Given this list of marker genes LILRA4, DTX3L (NCBI Gene Id 151636), IL6R, GBP2, IL22RA2, PROS1, IGF1, MCU, FPR2, EPHA4, CCL21, PDCD4, FLOT1, KCNK13, WNT4, SEMA5A, PRDX2, FFAR4, IRGM, ZNRF1, ANXA1, ALOX5, MAP3K8, HLA-B, CEACAM1, SIRT2, FCRL3, AREL1, EFNB2, NLRC5, VPS35, TNFRSF11A, TRIL, MIR21, PRKD2, LACC1, PLCG1, MICOS10-NBL1 (NCBI Gene Id 100532736), NKG7 (natural killer cell granule protein 7), MIR140, TRPV4, ARTN, CLPB, SETD6, IRF5, RNF31, APOA1, CALHM6, PGLYRP2, RB1, MIR520B, PYDC5, ADAM17, RARRES2, ADORA2A, JAK2, GSDMD, GNAS, TRIM38, CD96, MMP3 (NCBI Gene Id 4314), SUCNR1, STAT5B, DHX9, STAT3, RNF26, AP3B1, CCL4 (C-C motif chemokine ligand 4), CD36, CD47, ENPP3, KLKB1, SPHK1, ARMH4, PTPRC, CAMKMT, CASP1, PPARA, DAGLB, IRF7, STMP1, NLRP12, CASK, SHARPIN, XCL1, IL17A, CDH5, FCGR2B, CCR6, CPT1A, SLC39A8 (NCBI Gene Id 64116), PJA2, PYCARD, ABCC1, ANXA2, PSMA6, TLR2, FOSL1, NAGK, JAM3, MIR181B1, APCS, SH2D1B (NCBI Gene Id 117157), NMT1, IL6ST, IFIH1, MAPK14, DTX4, IL37, MOSPD2, APPL2, SQSTM1, TSPAN32, LAMP1, AIF1, UFL1, C5, ELF4, CTTN, AKIRIN2, DRD2, PHB1, HPX, NFKB1 (NCBI Gene Id 4790), FGF4, CD109, LETMD1, IL18RAP, ZDHHC5, MIR200C, RAC2, PLA2G2A, FYN, HLA-DRB1, OAS3, PLA2G2D, SOCS5, ACOD1, NCR1, APOE, MGLL, HDAC6, GRK7, GDI1, APPL1 (adaptor protein, phosphotyrosine interacting with PH domain and leucine zipper 1), STING1, RAB11FIP2, MIR708, CAMK2N1, TMX1, SLC15A4, PLAT, TRAF3, MIR16-1, YWHAE, STX3, HCK, SNCA, DHX58, PGF, A2M, AIM2, SERPINB9, TEK, PTK2, GNAT1, PELI1, GATA6, ABHD12, CPTP, CHD8, MFHAS1, RTN4, SLC15A2, TRIM32, PGC, TAC1, SPI1, DNASE1 (deoxyribonuclease 1), BCL6B, MIR31, IL17RB, IKBKB, TLR8, UBQLN1, DUSP3, PQBP1, INAVA, MIR206, S100A8, TNFSF18, MIR138-1, DAGLA, CD274, NT5E, MIR30C2, HAVCR2, DEFB131A, GUCY2D (NCBI Gene Id 8145), CORO1B, CARD9, USF1, METTL3, MAP2K1, VEGFD, IRAK2, ITGA2, IRF3, WNT3, PTGIS, SERPING1, RHBDD3, PTGER4, CASP6, AURKB, ZDHHC1, FGF18, CD55, ATG12, RNF125, PPP2CA, MIR431, KRT1, RIPK2, PIK3R1, LYPLAL1, DDX3X, PTPN11, WFDC1, SERPINB4, TIGIT, ADORA2B, TLR10, MMP8, NTRK3, HEXIM1, SELENOK, CEBPB, TNFAIP6, CNTF, MMP28, SFPQ, MMP9, FGG, BMP6, HLA-F, CXCR3, TLR7 (toll like receptor 7), TAFA3, FGF10, UFD1, VAMP3, SOX15, ARNT, PPP1R13L, NPLOC4, MIR22, IFNLR1, PLA2G7, KLRD1, DDX39A, TMEM126A, TNC, RAET1E, RTCA, RIPOR2, LRRK2, TNIP1, MIR424, SERPINC1, RBM47, GRK4, SHPK, IFNG, FNDC4, VAMP2, SLIT2, HERC5, DVL1, GGT2P, HSPB1, NDFIP1, DDX60, HRG, MIR361, POU4F2, TYROBP, IL21, TRIM3, NOP53, KLRC3, GPS2, SEMA3F, RPS19, CXCL13, REG3G, YTHDF3, TRAF3IP3, AKT1, MIR15B, IL1R1, SLC8B1, IL12RB1, DUSP10, THBS4, BRCC3, INPP5D, PUM1, MIR146A, FUT7, ARRB2, NLRP4, CD300E, CCL19, NAIP, LRIG2, IDO1, MARK4, DSCAM, EXTL3, CX3CR1, MYCBP2, TLR3 (toll like receptor 3), PGLYRP1, KIR2DS2, YWHAZ, GP1BA, SIGLEC16, PYDC1, MUL1 (NCBI Gene Id 79594), FOXF1, TICAM2, VTN, HCFC2, IL4, CYBA, EMILIN1, CASP12 (caspase 12 (gene/pseudogene)), IL20, CYRIB, MIR766, MIR19A, PIK3CG, MIR657, MAPK8, POMC, MBL2, MET, DDX41, LBP, PPARD, ZNFX1, TRAFD1, RICTOR, KLRB1, GFI1, ABHD8, CCN3 (NCBI Gene Id 4856), RNF115, EIF2AK4, CD37, APOBEC3F, DUSP1, PTGER3, BRD4, LGALS9, CD160, FGR, NLRP7, TNIP2, KLK5, LILRA2, CAMK1D, NEO1, PIK3AP1, TICAM1, DNM1L, PTPN22, ADAMTS18, MIR205, GHRL (ghrelin and obestatin prepropeptide), SCIMP, IFNK, MED1 (mediator complex subunit 1), PLK2, SIGIRR, IL1RL1, AZU1, FFAR3, NMT2 (N-myristoyltransferase 2), SEC14L1, FLOT2, HPSE, POLR3G, RASGRP1, FGFR1, TRAF3IP2, PERP (NCBI Gene Id 64065), EPPK1, NLRP5, SNX6, CD300A, CD180, C5AR2, PVR, MTUS1, EPHB2, VAMP7, HSPA1B, ESR1, PLA2G3, CARD16, TAFA5, PHB2, NLRC3, MIR4286, NLRP6, CLEC7A, GUCY2F, MIR19B1, PLAU, LPL, CTSC, CNTNAP2, CLEC12B, MIR200B, ACE2, GKN2, PSMA1 (NCBI Gene Id 5682), GPR108, MAP3K7, AOAH, ADORA1 (adenosine A1 receptor), GPR4, OSM, TASL, C2CD4A, IL1B (NCBI Gene Id 3553), YES1, NT5C2, ADAM8, GGT1, PAK1, NLRX1, RAC1, HMGB1, MYOZ1, CD81, SLIT1, ZP3, APOH, MARCHF5, MAPK7, OXSR1, AIPL1, AJAP1, ROBO1, HLA-E, OTUD4, MIR223, SCARA3, TPBG, TMEM102, C2CD4B, USP27X, MPP1, GRB2, CSF1, FEM1A, ATOH7, RBM14, MIR20A, LSM14A, EPG5, KAT5, NBL1, TARBP2, MIR181A2, LACRT, GIGYF2, N4BP1 (NCBI Gene Id 9683), IL10RA, KCNJ8, GRN, KIR2DL4, CTSS, PARP14, BRAF, CLASP1, IER3, NR1H2, TNFAIP3, CCL3, LILRB1, SH2D1A, NECTIN4, SMIM30, NFKBIA, TREM2, SERPINE1, RNF34, PML, USP38, UBASH3B, PTPRJ, MIR920, IL17F (NCBI Gene Id 112744), PDGFA, MIR145, ADGRA2, ERAP1, IL1RL2, MIR4691, DROSHA, CXCL17, NR1D2, KLK3, MEFV, C3AR1, EDN1, VSIG4, TRIM21, YTHDF1, CCL24, AGER, SLC6A3, FOXP3, AGTR1, GSTP1, PDPK1, TRIM22, TMSB4X, NFKBIL1, CXCL6, PBK, ELMOD2, XRCC6, FANCA, APOBEC3G, IKBKE, FADD, LY86, POLR3D, LYAR, NONO, NOTCH1, IL34 (interleukin 34), HSP90AA1, NRP1, PLAUR, LGALS2 (NCBI Gene Id 3957), CD226, NCF1, TRIM56, S100A12, CREB3L3, ASH1L, TTBK1, EIF2AK2, NR1H3, MICA, RNF144A, PSMB4, MACIR, TLR5, MAVS, FAM76B, CASP4, DRD3, SELENOS, CD9, SBNO1, POLR3C, SIN3A, LPAR1, TSPAN8, TNR, VEGFB, NFE2L1, F2, GATA3, RGMA (NCBI Gene Id 56963), IL23R, CSNK1A1, KLRK1 (NCBI Gene Id 22914), SCGB1A1, CD74, PLXNA3, PIM1, ZC3H12A, RORA, BAP1, FABP4, IL18, NTF3, MIR149, TUBB2B, SNX4, PYHIN1, ZMPSTE24 (NCBI Gene Id 10269), MIR590, METRNL, OTULIN, PAK3, ZDHHC4, MYD88, PROC, F2RL1, HSP90B1, NPY5R, SCARF1, USP17L2, ALOX12 (arachidonate 12-lipoxygenase, 12S type), OASL, F12, PF4, NR5A2, MIR3909, SMPDL3B, BIRC3, TRIM15, GRAMD4, IL15, ADTRP, SARM1, CD1D, POLR3B (RNA polymerase III subunit B), SBNO2, XRCC5, NUPR1, SLC15A3, TLR4, GBP5, AHSG, CMA1, ZDHHC18, CNOT7, GGT3P, RIN3, F11, TIRAP, USP50, SPAAR, TREX1, NOD1, OGT, WNT5A, SLC19A1, PLXNA4, ZCCHC3, CLEC4E, EDN2, NFKBIZ, IFI16, PCBP2, TRIM41, TNFSF11, ITCH, SLAMF6, NCKAP1L, AKNA, GPR31, TIFAB, CCDC134, SETD4, TRIM44, CR1, SERPINF2, MIR26A1, GAS6, IRF1, FURIN, SMAD3, RHBDF2, CYLD, GPR17, GPX1, IRAK1, MVK, TNIP3, PTPN6, SASH1, OSMR, MIR144, MAP2K2, DEFB118, UNC93B1, KLF4, ROBO2 (NCBI Gene Id 90370), LATS1, BCL10, PTPRS (NCBI Gene Id 5802), MMRN1, USP18, MIR92A1, VEGFC, PTEN, ANO6, SCG2, CRK, CAV1, ATG5, LPCAT3, PPP2R3C, KREMEN1, CFH, WASHC4 (WASH complex subunit 4), FGF2, PDGFB, FIGNL2, MIR195, MIR199A1 (NCBI Gene Id 406976), RNF39, USP29, GHSR, DSG2, CCDC92, TBK1, CXCL12, CALR, FCGR1A, TXK, CASP8, STX4, ADAM10, TLR6, FCER1G, GRIN3A, HLA-A, CDC37, SIGLEC10, LATS2, FAP, NINJ1, NLRP14, CLNK, ST3GAL4, MIR17, CSF1R, FGB (NCBI Gene Id 2244), IRF4, CXCL10, SPP1, MIR15A, LRFN5, CD300LF, F2R, CAPN3, IL22, TRIM62, IFI35, OTOP1, TSPAN6, CLEC12A, NPY, BCL6 (BCL6 transcription repressor), PPARG, PYDC2, BTK, C3, RASGRP4, C5AR1, ACP5, POLR3F, PPM1B, ERCC6, EIF4E2, MIR222, ZNF580, ISG15, PAK2, TRIM11, RSAD2, TRAF3IP1, SLC12A2, COLEC10, MIR105-1, CD300C, GIT1, TRIM31, CREBBP, CPB2, PARK7, MAPKAPK3, EP300, PLSCR1, SLC46A2, USP15, SYT11, DNASE1L3 (deoxyribonuclease 1L3), GJD4, TNFSF4, ADAR, CCL2, NEDD9, MIR488, NLRP13, TNFSF14, WDFY1, IL10, IFNB1, BECN1 (beclin 1), DPP4, ZDHHC12, RIPK1, HGF, TAX1BP1 (Tax1 binding protein 1), PTPRO, MIR6869, TRIB1, P2RY12, PDGFRA, BIRC2, TRAF6, LRCH4, NR1D1, STAP1, TNFRSF1A, SLAMF1, FGF16, PRKCD, F3 (NCBI Gene Id 99486), CRTAM, IL2RA, COLEC11, CCN4, PDGFD, NEK7, KLRC4-KLRK1, CCL5, PLG, PARP9, NOS3, XIAP, COLEC12, GBA1 (NCBI Gene Id 82008), FANCD2, IL6, SERPINE2, GRK1, MIRLET7G, WNK1, STAT1, P2RX7, TOMM70, DRD1, TNF, STAT5A, RIGI, ZNRF4, NLRP9, IRAK4, ABHD17A, PARP1, ARG1, PSPC1, MIR34A, NLRP2, FAM3A, PHLDB2, AKIRIN1, PRKCE, INS, THBD, SOCS3, KLRC1, LYN, IL27, TAB1, PTPN1, CACTIN, HMGB2, IL12A, PTGES, TTLL12, S100A9, SPSB3, EVPL, RTN4RL1, MDK, CASP5, KARS1, LGALS1, VAMP8, BACE1, ETS1, ZBP1, NEAT1, STK39, CCR7, MIR187, MICB, IL17RA, SWAP70, NMI, SFN, ILRUN (inflammation and lipid regulator with UBA-like and NBR1-like domains, NCBI Gene Id 79138), KDR, SYK, SLAMF8, MMRN2 (NCBI Gene Id 79812), PPM1F, AP1G1, ROBO3, NAPEPLD, SMOC2, SPATA2, PTK2B, IL23A, FEZF2, NLRP10, GPRC5B, IPO5, KLRC2, MAPKBP1, GRID2, GBP1, EDNRB, SOD1, ECSIT, CYP19A1, IL2, CST7 (NCBI Gene Id 8530), S1PR1, KIF21A, TRIM6, NLRP1, MIR181C, LRP8, MEGF8, FBXL2, CDH13 (cadherin 13), P2RX5, IRAK3 (NCBI Gene Id 11213), SAMHD1 (NCBI Gene Id 25939), MMP26, NLRP2B, DAB2IP, ANGPT2, ZDHHC9, PTPN2, PADI2, ENPP4, HLA-G, MIR126, ZDHHC3, TNFAIP8L2, DDT, TYRO3, MIR221, MCPH1, AGT, TIFA, CCR1, EMILIN2, ARG2, PDE2A, LILRA5, SERPINB2, DHX33, PLA2G5, SH2B3, PDGFRB, FGL2, MAS1, KCNK6, NLRP8, NR1H4, TBR1, VAV1, PLCG2 (phospholipase C gamma 2), PTN, VEGFA, ZC3HAV1, PRKCA, APP (NCBI Gene Id 351), TBXA2R, CREB3, SPN, CX3CL1, EREG, USP14, CCR2, PIK3R6, CEBPA, PUM2, FGF1, ELANE, GPR183 (NCBI Gene Id 1880), GPER1, CD200R1L (CD200 receptor 1 like), UBE2K, MSTN, FCN3, MATR3, RNF185, TNFRSF1B, ADAMTS12, MKRN2, NLRC4, MIR520E, CXCR4, MMP12, CLEC6A (NCBI Gene Id 93978), CELF1, SIRPA, FOXP1, RYK, STK24, RELA, HYAL2, C1QBP, ANKRD17, C1QTNF3, TLR1, NAGLU, CMKLR1, GBP3, RNF170, NLRP11, LAG3, IL33, HTR2A, DEFB114, MIR1298, NECTIN2, REG3A (NCBI Gene Id 5068), PPP6C, LRSAM1, TLR9, SAA1, INPP5F, MAP2K6, CALHM2, MGST2, CCL26, CD200R1, S100A14, HSPD1, SELE, LEP, C1QTNF1, IL12B (NCBI Gene Id 7907), KLK7, FCN2, HSPA1A, ERBIN, RAB7B, NFE2L2, LDLR, F7, CTNNA2, RNF135, ATAT1 (NCBI Gene Id 79969), NOVA2, TRIM25, RNF216, MYOD1, S100A7, AHR, TKFC (NCBI Gene Id 26007), KNG1, TSLP, CLASP2, OAS1, SEMA7A, MIR204, THBS1, CD300H, KLRC4, MNDA, MIR210, LTA, MIF (NCBI Gene Id 4282), MAPK13, GPSM3, CXCL8, ELP6, MIR302E (microRNA 302e), MAPK1, RPS6KA3, CHUK, IL20RB, CD14, PPT1, DUOXA1, TRIM45, CD28, CARD8, FXR1, CERS2, IL16, STAT2, BCR, MAPKAPK2, SPINK5, NCR3, TRIM5 (NCBI Gene Id 85363), CCL1, CASR, BMPR2, BST1, UACA, PTPRF, DCST1, C1QTNF12, ADA, HSPA8, MAPK3, LY96, WNT3A, TRADD, FCN1, CADM1, BPIFB1, PLA2G10, RFTN1, RABGEF1, ALOX15, SRC, IL22RA1, CCL7, DAPK2, DUOXA2, ISL1, MIR26B, TGFB1, ADIPOQ (adiponectin, C1Q and collagen domain containing), TRIM65 (tripartite motif containing 65), LGMN, CASP3, OPTN, MIR128-1, CLOCK, CD200, MIR141, RAET1G, GPR18, FGA, LRRC19, CGAS, NLRP3, AARS2, NOD2, FOXA2, EDN3, SMPDL3A (sphingomyelin phosphodiesterase acid like 3A), YTHDF2, PRKD1, GREM1, SUSD4, FFAR2, LTF, RIOK3, ZDHHC11, CEP63 (NCBI Gene Id 80254), IL13, RTN4R, PTGS2, P2RX4, GPATCH3, DNAJA3, DEFB124, PRKDC, ALPK1, LGR4, TREML4, LAMP2, MIR142, PRKG1, TFPI, HOPX, BANF1, LRRC14, KIAA0319, here is a description of the gene set: Human Gene Set: GOBP_REGULATION_OF_RESPONSE_TO_EXTERNAL_STIMULUS studied in species Homo sapiens Any process that modulates the frequency, rate or extent of a response to an external stimulus.